Given this list of marker genes Hdac6 (NCBI Gene Id 20374), Nrp1, Megf8, Cxcl12, Vegfa, Plxna3, Ryk, Wnt5a, Wnt3, Slit1, Sema5a, Dscam, Plxna4, Wnt3a, Sema3f, Sema3a, Bmpr2, here is a description of the gene set: Mouse Gene Set: GOBP_REGULATION_OF_AXON_EXTENSION_INVOLVED_IN_AXON_GUIDANCE Any process that modulates the frequency, rate or extent of axon extension involved in axon guidance. species: Mus musculus